Given this list of marker genes MICALL2, NFKB1, PALLD, MAGI1, RARA, LRRC10, MYOT, LDB3, PDLIM2, TRPC6, RELA, PTPRT, CACNA1C, PRICKLE4, PKD2, KCNN2, KCNA5, CSRP1, PPARG, DAG1, CSRP3, MYPN, XIRP2, CSRP2, PDLIM5 (PDZ and LIM domain 5), TTN, TRPC5, SYNPO2, PDLIM3 (PDZ and LIM domain 3), NRAP, PDLIM7, PDLIM1, PKD2L1, PDLIM4, PROM1, MYOZ1, ADORA2A, CACNA1D, here is a description of the gene set: species: Homo sapiens Human Gene Set: GOMF_ACTININ_BINDING Binding to actinin, any member of a family of proteins that crosslink F-actin.